The following is a description of a gene set: species: Homo sapiens Human Gene Set: MODULE_218 Genes in the cancer module 218., and this is the list of marker genes: SLC34A1, SLC16A2, SLC16A4, SLC12A1, SLC6A1, SLC12A3, SLC20A1, SLC16A3, SLC10A1, SLC10A2, SLC16A7, SLC6A4, SLC16A8, SLC6A3, SLC15A1, SLC6A11, SLC24A1, SLC6A2, SLC17A2, EBP